Given this list of marker genes Emc9, Mmgt1 (membrane magnesium transporter 1), Timm10, Oxa1l, Emc3, Cox18, Emc10 (ER membrane protein complex subunit 10), Emc1, Emc2, Emc6, Emc8, Emc4, Emc7, Timm9, Get3, Mtch2, Mtch1, here is a description of the gene set: studied in species Mus musculus Binds transmembrane domain-containing proteins and mediates their integration into a membrane. Mouse Gene Set: GOMF_MEMBRANE_INSERTASE_ACTIVITY